The following is a description of a gene set: Second messengers are generated within the cell as a downstream step in signal transduction cascades initiated by the interaction of an external stimulus with a cell surface receptor. Common second messengers include DAG, cAMP, cGMP, IP3, Ca2+ and phosphatidylinositols. part of: Signal Transduction species: Homo sapiens Reactome Pathway: Intracellular signaling by second messengers, and this is the list of marker genes: AKT1, REST, PSMC3, TGFA, LCK, EZH2, MOV10, PRKCD, FGF10, CSNK2A2, BTC, STRN, RRAGA, SUZ12, PIK3R3, FGF23, VAPA, KIT, FGF4, IRS1, AKT2, RBBP7, ATF2, ADCY4, NTRK2, UBA52, GRB2, RICTOR, AKT1S1 (AKT1 substrate 1), MDM2, PTPN11, PDPK1, IRS2, MTA3, PIK3R5, CHD3, RRAGC, IL1RL1 (NCBI Gene Id 9173), ITPR3, MAF1, TRAT1, PSMC6, FGF22, MET, PDGFB, VAV1, HDAC1, HDAC3, FGFR1, FGF2, CAMKK2, AKT3, NRG1, SALL4, CDKN1B, GSK3A, LAMTOR4, FLT3LG, BMI1, PDGFRA, NRG4, CBX8, MTOR, EGFR, CBX2, PPARG, MBD3, FGF20, FLT3 (NCBI Gene Id 2322), FGF16, NR2E1, FOXO1, MAPK3, PRKACA, PSMC4, LAMTOR5, PRKACG, ATN1, MAPKAP1, ADCY9, RNF2, CNOT6L, RRAGB, SGK1, CD19, PSMA4, KL, ESR2, TNRC6A, PRKCE, PDE1B, GATAD2B (NCBI Gene Id 57459), PDGFA, PTENP1, RNF146, GATAD2A, ADCY1, MIR20B, PIK3AP1, PLCG1, FGF6, GAB1, IER3, RPTOR, PSMD6, FRS2, ESR1, PRKACB, CAMK2D, TRIB3, PRKCG, RAC1, FGF7, PPP2CA, MIR106A, RPS6KB2, ADCY8, MIR19B1, PSMB1, GAB2, PIK3CB (NCBI Gene Id 5291), PPP2R5B, RING1, SEM1, CAMK4, RAC2, PSMD12 (NCBI Gene Id 5718), PIK3R2, AGO3, HGF, CD28 (NCBI Gene Id 940), PSMD14, PTEN, TNRC6C, ICOS, FGF19, TSC2, INS, PSMA3, CASP9, NTF4, BDNF, PDGFRB, FGF18, AGO4, FOXO4 (forkhead box O4), CALM1, IRAK1, XIAP, FRK, MIR106B, USP7, PHC3, PIP5K1B, MIR214, NTF3, ADCY3, PSMD7, NBEA, PHC1, CBX6, PSMA2, CAMK2B, TP53, HDAC5, GRK2, RCOR1, PDE1C, PSMD13, TRIM27 (tripartite motif containing 27), HBEGF, PSMA7, MIR21, AREG, LAMTOR3, PSMC5, RPS27A, PHLPP2, FYN, PPP2R1A, AGO1, PSMA5, ERBB2, PSMB2, MIR93, ERBB4, FGF8, PPP2R5C, NTRK3, MIR19B2, CHUK, ITPR1, PIP4K2C, FGFR3, MIR19A (microRNA 19a), ADCY5, IL1RAP, PPP2CB, SNAI2, PSMB3, PIP5K1C, NEDD4, SLC38A9, PIP4K2A, FGFR2 (fibroblast growth factor receptor 2), MIR205 (NCBI Gene Id 406988), INSR, ADCY6, CD86, SRC, ITPR2, PSMA1, LAMTOR2 (NCBI Gene Id 94954), MECOM, ERBB3, TNRC6B, RBBP4, GSK3B, CAMK2A, KDM1A, PRKAR2A, PSMD11, CAMK2G, PIK3CA, SNAI1, KITLG, EGF, M, PIP4K2B, UBB, USP13, FOXO3, PSMA6, OTUD3, EREG, PSMB6, PIK3R6, HDAC7, FGF3, ADRM1, MIR26A1, PIK3CD, PIK3CG, MTA1, FGF5, AGO2, CHD4, PSMB7, WWP2, PSMC1, PRKX, NR4A1, MIR26A2, CREB1, EED, KLB, IL33, CDKN1A, PHLPP1, MYD88, PSMD8, PREX2, CBX4, PML, PSMB5, MIR20A, TNKS, RHEB (NCBI Gene Id 6009), PSMC2, RHOG, MAPK1, PHC2, TNKS2, HDAC2, MLST8, CD80, STUB1, FGF1 (NCBI Gene Id 29961), PIP5K1A, FGFR4, PRR5, JUN, ADCY2, PRKAR1B, PPP2R1B, MIR22, PRKCA (protein kinase C alpha), EPGN, IRAK4, PIK3R1, PRKAR2B, AHCYL1, PDE1A, PPP2R5E, PSMD3, N, SCMH1, MKRN1, PSMD1, ADCY7 (NCBI Gene Id 113), MIR17, FOXO6, LAMTOR1, TRAF6, FGF17, MTA2, PSMD2, NRG3, CAMKK1, UBC, PPP2R5A, RRAGD, KPNA2, BAD, CSNK2A1, EGR1, NRG2, CSNK2B, MIR25, PSMB4, PRKAR1A, FGF9, THEM4, PPP2R5D